Given this list of marker genes Aaas (achalasia, adrenocortical insufficiency, alacrimia), Seh1l, Nup85, Nup42, Nup58, Nup210, Nup54 (NCBI Gene Id 269113), Pias4 (protein inhibitor of activated STAT 4), Nup93, Ndc1, Nup133, Nup205, Rae1, Nup155, Sumo1, here is a description of the gene set: Reactome Pathway: SUMOylation of SUMOylation proteins species: Mus musculus electronically inferred by orthology from the curated human pathway This event has been computationally inferred from an event that has been demonstrated in another species.<p>The inference is based on the homology mapping from PANTHER. Briefly, reactions for which all involved PhysicalEntities (in input, output and catalyst) have a mapped orthologue/paralogue (for complexes at least 75% of components must have a mapping) are inferred to the other species. part of: SUMO E3 ligases SUMOylate target proteins